The following is a description of a gene set: Human Gene Set: CP2_01 Genes having at least one occurrence of the motif GCHCDAMCCAG in the regions spanning 4 kb centered on their transcription starting sites. This matches the TFCP2 transcription factor binding site V$CP2_01 (v7.4 TRANSFAC). studied in species Homo sapiens, and this is the list of marker genes: SOX12, COL1A2, RBKS, SEMA4A, CDK5R2, FGD4, FOXA2, EIF1, MEX3B (mex-3 RNA binding family member B), NHSL2, RSPO2, TNKS1BP1, LSM12, ACBD5, NKPD1, SLC39A13, STAG2, DOCK9, ASB2, METTL8, TSPOAP1, PLEKHN1, SMARCA2, DMTF1, CHST14, DLL4, PHF7, MYBPC3 (NCBI Gene Id 4607), LY6H, NEFM, SRCIN1, NCDN, HOXB9, SHISA7, CSF2, RPSA, SATB1, LRCH4, ATP2A3, ELAVL2, FOXN1 (NCBI Gene Id 8456), DCHS1, TMEM43, WDR81, GLYR1, DCAF17, PCIF1, NACC1, HIPK2, EED, PPP1R12A, GUCA2B, MAPKAP1, ETV5, HSD3B7, PSMA5, FBXO24, CRYBG2, NPAS4, DHH, HOXC5, TCF7L2, DDX17, TJP2, RASGRP2, KIF1C (kinesin family member 1C), ARF3, ICAM4, KCTD15, NFKBIZ, ALOX12, SORT1, LIM2, RAB10, CITED1, BRSK1, GLI1, PHLDB3, MIR22HG, NUFIP2, IL11, ARF6 (ADP ribosylation factor 6), TIMELESS, RGS8, E2F4, CREB3L2, DBP, CADM2, RHOQ, GFOD2, TRMT1, SHKBP1, VAMP2, HR, WNT3, CALD1, VKORC1L1 (NCBI Gene Id 154807), STX1A, PPP2R2B, GPR173, HEBP2, RAB30, BCOR, SMOX, MDFI, CLSTN2, SLC23A2, ANXA8, GRM7, RGS3, USP1, SCUBE3, PRR16, KIF5A, TGIF1, TGFB1I1, IGDCC4, VEZF1, DAB1, RNF111, NDUFS4, CHD4, PDE2A, CDH2, ANKRD13B, CNN1, RBM6, KRT78, HIF3A, COL1A1, CEND1, RTN1 (NCBI Gene Id 8108), PRDM13, NOL4, ETV3, EWSR1, BMF, SRSF7, EGFL6, SOBP, ARHGAP45 (Rho GTPase activating protein 45), SOX10, ZIC2, B4GALT2 (beta-1,4-galactosyltransferase 2), CABP1, RHBDD3, IGFBP6, KMT2E, IL1RAPL1, SYT6, GATA1, CEBPB, TNXB, LAMB2, UBE4B, RPL41, SPEG, CA14, ZNF532, SLC35E1, ZC3H10, RGMA, ATF3, ODC1, HOXC8, DPY30, MAP1A, HECTD4, SF1, STRA6, ATP6V1E2, CDK8 (cyclin dependent kinase 8), MCMBP, CALM3, CA9, DDIT4, ITGB1BP2, GNAS, DDR1, PRELP, PTOV1, HPSE2, JPH2, RNF145, CHCHD4, NGF, EDA, NCKAP1L, DCTN1, ZNF771, MOSMO, LIN28A, PPM1N, GRHL2, SALL1, PLEC, COL11A2, ADIG, SPATA25, GRHL3, COX8C (NCBI Gene Id 341947), RCOR2, SLC8A3, EPC1, LIMD2, SUMO2, CAV3, DSG3, SPATS2, ZBTB9, PANK2, PMP22 (peripheral myelin protein 22), BABAM2 (BRISC and BRCA1 A complex member 2), GREM1, LIN54, SPOCK2, VAPA (VAMP associated protein A), RORC, NNAT, KCNN2, SOCS1 (suppressor of cytokine signaling 1), JADE3, PAK2, HDAC9, POM121L1P, SOD3, DAB2IP, ZNF710, GATA3, BAP1, EHF, ESM1, RTN2, TSC22D4, EFEMP2, LTBP3, C1orf43, IRS4, SLITRK5, ABHD4, RHOA, SLC25A35, GLG1, FKBP2, GPD1, CSNK1A1L, CRMP1, RHOG, TNS2, SLC41A1, ENO1 (enolase 1), NLGN2, TUFT1, VCP, PPP6C, DHRS3, GPC3, PAX6, MAPK3, CRTAC1, SLC25A23